The following is a description of a gene set: Binding to the oxidized form, NAD, of nicotinamide adenine dinucleotide, a coenzyme involved in many redox and biosynthetic reactions. studied in species Mus musculus Mouse Gene Set: GOMF_NADPLUS_BINDING, and this is the list of marker genes: Glud1, Parp14, Sirt5, Uxs1, Ehhadh, Cryl1, Sirt2, Sirt4, Hpgd, Aldh1a3, Sirt7, Sirt3 (NCBI Gene Id 69497), Sirt1, Hadh, Hadha, Sirt6